The following is a description of a gene set: The chemical reactions and pathways involving L-leucine, 2-amino-4-methylpentanoic acid. studied in species Homo sapiens Human Gene Set: GOBP_L_LEUCINE_METABOLIC_PROCESS, and this is the list of marker genes: BCAT2, IVD, HMGCL, AUH, DAO, MCCC1, HMGCLL1, BCKDK, MCCC2